Given this list of marker genes Oxsr1, Selenok, Tnfrsf14, Abl2, Xcl1, Adam17, Cd99l2 (NCBI Gene Id 56789), Pycard, Tnfsf14, Aif1 (allograft inflammatory factor 1), Ccr7, Rhoa, Cxcl10, Coro1a, Dock8, Adam10, Ccr2 (C-C motif chemokine receptor 2), Med23, Itgb3, Wnt5a, Ccl20, Fadd, Adam8, Abl1, Ccl5, P4hb, Ascl2, Itga4, Cxcl13, Spn, App, Wnk1, Stk39, Tnfsf4 (tumor necrosis factor (ligand) superfamily, member 4), Cxcl12, Lgals9, Ccl21a, Tmem102, here is a description of the gene set: species: Mus musculus Any process that activates or increases the frequency, rate or extent of T cell migration. Mouse Gene Set: GOBP_POSITIVE_REGULATION_OF_T_CELL_MIGRATION